The following is a description of a gene set: Human Gene Set: GOBP_MEIOTIC_SISTER_CHROMATID_COHESION The cell cycle process in which sister chromatids of a replicated chromosome are joined along the entire length of the chromosome during meiosis. studied in species Homo sapiens, and this is the list of marker genes: RAD51C, GTF2B, SGO2, PPP2R1A, HORMAD2 (HORMA domain containing 2), SMC3, HORMAD1, BUB1B, PPP2R5D, SMC1A, REC8, RAD21, PPP2R1B, MEIKIN, STAG3, PPP2R5C, BUB1